Given this list of marker genes SSH1, NPTXR, NRP2, ARID3B, POU2AF1, AGXT, ITPRID2, PAQR4, COLCA1, SLC7A5, NPTX1, GSG1L, PDX1, PDE1A, F12, PI4KB, NIBAN2, SH2B3 (SH2B adaptor protein 3), LASP1, CTPS2, LENG8 (leukocyte receptor cluster member 8), COP1, MTCL2, CFL1, UCP2, PHYHIP, CDC42BPA, SYNGAP1, PITPNM3, CSDE1, PACS1, EDC3, RAB12, RETREG1, RAB30, CREB3L2, CSN2, KCNC1, ARK2N, LPO, ULK2, DSCAML1, CCDC34, NAV2, SLC25A20, E2F1, ATP1B2, WIPF1, ZBTB7C, VAX1, STEAP3, AP1S1, KCTD2, TAPBP, RAB11FIP5, UBE2D3 (ubiquitin conjugating enzyme E2 D3), MROH9, RABGEF1, INO80D, IL17REL (interleukin 17 receptor E like), TENM4, C20orf96, POLR2F, SMARCD1, PSMB2, POU3F4, ZNF333, NFAT5, RNASE13, GPATCH2L, SLC24A2, HMGN4, GIT1, CUL4A, CD3E, XYLB, PSME3, GNAO1, RPA1, ABCG4, FNDC5, NIBAN3, CASQ1, FCGR1BP (Fc gamma receptor Ib, pseudogene), MAP3K9, SLC9A9, WIPF3, BCL9L, IL2RG, CDH26, DYRK2, UBQLN4, LZTS1, ANKRD52, SHC3, STMN1, FILIP1L, DAGLA, NKD1, ATRX, SH3PXD2A, TFDP2, INKA2, PRR12, VSTM2B, ZFP64, SFMBT1, SDC3, CDC27, UBE4B, KCNIP3, LILRA1, ADAM12, SEMA5A, TNNI1, AUTS2, SIPA1L1, RAPGEF1, OSER1, RPH3A (NCBI Gene Id 22895), PARD3B, NFIX, CYB561D1, CLIC5, NRN1 (neuritin 1), RORA, S100A16, INO80C, C1orf210, CNNM3, DNM1, ABTB1, SLC8A2, WDTC1, KCNE4, NOVA2, GATA4, SPRY4, SLC1A5, IQSEC3, AAK1, SYP, ZMIZ1, CD200R1, IL17F (NCBI Gene Id 112744), TMEM184B, LMOD1, F9, GFAP, CD300LD-AS1, RIMS3, SMPD3, RHOC, RUNX3, AKT1, ISCA2, FARP1, ADCY7, SREBF2, VWC2, MVB12B, TRIM67, EYA3, ZIC4, RPGRIP1L, KSR2, PLXNA4, BRWD3, C1orf198, ZNF827 (zinc finger protein 827), NPLOC4, ATXN2L, NACC2, YBX2, SPRR4, ZNF703, ARHGAP6, NDUFA4, ZDHHC9 (NCBI Gene Id 93950), PLEKHO2, HEBP2, DUSP4 (NCBI Gene Id 1846), KLHDC8A, ADD1, IMPDH1, SDK1 (sidekick cell adhesion molecule 1), HPCAL4, PIANP, KRT75, IRF2BP1, HECTD4, TOM1L2, FMNL3, PDE4A, SMARCC2, DTNB, MEX3A, TNRC6B, NALF2, TP53INP2, BCR, here is a description of the gene set: Genes predicted to be targets of miRBase v22 microRNA hsa-miR-6797-5p in miRDB v6.0 with MirTarget v4 prediction scores > 80 (high confidence targets). species: Homo sapiens Human Gene Set: MIR6797_5P from publication Chen Y, Wang X (PMID 31504780)